Given this list of marker genes HADHB, ACAT1, HADHA, SCP2, ACAT2, ACAA2, ACAA1, here is a description of the gene set: species: Homo sapiens Human Gene Set: GOMF_ACETYL_COA_C_ACYLTRANSFERASE_ACTIVITY Catalysis of the reaction: acyl-CoA + acetyl-CoA = CoA + 3-oxoacyl-CoA.